The following is a description of a gene set: from publication Menzel O, Migliaccio M, Goldstein DR, Dahoun S, Delorenzi M, Rufer N (PMID 16951325) Human Gene Set: GSE5142_HTERT_TRANSDUCED_VS_CTRL_CD8_TCELL_LATE_PASSAGE_CLONE_UP Using CD8+ T lymphocyte clones over-expressing telomerase weinvestigated the molecular mechanisms that regulate T cell proliferation. Transduction and subcloning procedures were performed on CD8 + naive T-cell clones isolated from two different healthy individuals aged between 30 to 35 years (HD1 and HD2). T-cell cloneswere transduced to express hTERT/GFP or GFP alone. HD2 was profiled on U133Plus 2.0 and submitted as a separate GEO series. Genes up-regulated in CD8 T cells: early passage clone over-expressing TERT versus late passage control. species: Homo sapiens, and this is the list of marker genes: NOP56, RAD54B, DDIAS, MRPL41, MID1, MRPL47, NAA38, DNAJC24, APIP, SRL, CKS2, LSM3, FH, NCAPH, CENPL, TOP2A, CRMP1, CORO1C, ZNF367, CENPN, FERRY3, RILPL2, PSMD8, DAP3, SF3A3, NDUFS8, ABI3, ZNF296, RGS1, CASP1, GEMIN2, ARL6, WEE1, KATNB1, TAMM41, POGLUT2, SLIRP, SYCE2 (NCBI Gene Id 256126), TTF2, PRKRIP1, SNRPB2, TJP2, SLC25A4, E2F8, TBCD, CDCA5, MYBBP1A, LRRC75A, MRNIP, RRP15, XRCC6, PRIM1, MRPL27, SMARCAD1, DSN1, CTC1 (CST telomere replication complex component 1), TIMM17B, MZT2B, SERPINB9, DTYMK, MFSD2A, METAP2, CIBAR1, CASP3, ITGB3BP, GINS2, HIRIP3, GAR1, POLR2I, ELOA, TEX9, NUDCD2 (NudC domain containing 2), MCM8, RMDN3, LANCL2, NUP107, FDPS, TMEM126A, LMAN1, SKIC8, PSMD14, PIM2, TBC1D19, NDUFV3, NAF1, PPP1R14B, PMVK, ECI2, PLPP1 (phospholipid phosphatase 1), HSP90AA1, TFE3, NUP205, PBK, UQCC6, RPS27L, BORA, ZGRF1, HINT1, CCNA2, LSS, SEC11C, NDUFB7, CEP89, MKI67, NUDT2, SEC61G, MASTL, ABHD14A, RHOQ, DEPDC1B, DKC1, BHLHE40, RNF157, FIRRM, DMWD, STMN1, SMARCA4, HTT, BRCA2, WDR43, CCDC34, SHMT2 (serine hydroxymethyltransferase 2), RRM2, HDLBP, FKBP5, ETV6, PACRGL, PIGF, KCNQ5, CMC2, NDUFA10, SAMSN1, AHCY, HSPD1, GTSE1, FRMD4B, NIFK, CDK6, TYMS, DHDDS, NMNAT1, SGO2, POLA1, MRPL21, CBX5 (NCBI Gene Id 23468), ACO2, PCBP4, MRPL39, DCUN1D5, PUS7L, HNRNPD, RAN, FABP5, MRE11, NUP85, FUCA2, PDSS1, COX5A, PMF1, MAP3K20, KNSTRN, GMNN, TSPAN2, ARHGAP21, VARS1, SMYD2, BORCS8, GTF2E2, TASL, CISD1, BCS1L, PRKCSH, APOO, DSCC1, UBE2S, GCSH, SNRPD1, RANBP1, NR2F6, SMYD5, KIF18B, KIF23 (kinesin family member 23), NDUFA12, PSPH, ZNHIT1, LMNB2, CENPS, E2F2, EHD1, DDX39A, FANCA, TEX15, TCP1, CISH, ALAS1, LAP3, LAG3, NKG7, MRPS15, SRP54